The following is a description of a gene set: species: Homo sapiens Human Gene Set: FAN_EMBRYONIC_CTX_EX_1_EXCITATORY_NEURON from publication Fan X, Dong J, Zhong S, Wei Y, Wu Q, Yan L, Yong J, Sun L, Wang X, Zhao Y, Wang W, Yan J, Wang X, Qiao J, Tang F (PMID 29867213), and this is the list of marker genes: CSRP2, PANTR1, SLA, MEIS2, LINC01102, EIF1B, ENC1